Given this list of marker genes Zfyve26, Il16, Alkbh4, Erhrt-ps, Gnai2, Sirt2, Arl3, Mplkip, Mplkipl1, Ankrd45, Ptch1, Cep44, Hnrnpu, Mical1, Ctnnd1, Pkn2, Flcn, Rnf8, Ttc23l, Jtb, Tbck, Wiz, Eml4, Foxl2, Klhl9, Arf6, Ralb, Plk1, Celf2, Tacc1, Arl8b, Defa24, Cenpf, Defa2, Klhdc8b, Pkn1, Mbd5, Cit, Apc2, Cdk1, Rab11fip3, Defa25, Spart, Septin7, Defa5, Poldip2, Ect2, Usp8, Exoc2, Mark4, Agbl5, Dctn3, Abraxas2, Vps4b, Spast, Exoc3, Nek2, Cenpc1, Ptpn13, Chmp4b, Rhoa, Keap1, Rala, Stk17b, Spag5, Ttc28, Dnm2, Erh, Ccdc66, Crmp1, Pkp4 (plakophilin 4), Cdc42, Birc6, Katnbl1, Stx2, Defa3, Pdcd6ip, Defa37, Katnb1, Shcbp1, Anxa11, Rcc2, Vps4a, Rdx, Lzts2, Defa41, Septin12, Gdi1, Rack1, Urb2, Mak, Chmp5, Prc1, Cenpe, Lats1, Sccpdh, Chmp1a, Rap2a, Chmp6, Defa28, Dapk3, Chmp3, Chmp2a, Gnl3, Psrc1, Tex14, C9orf72, Cep126, Entr1, Ddx11, Exoc5, Chmp2b, Arl8a, Txndc9, Rab11fip4, Pitpnm1, Zfyve19, Ssh1, Bcl3, Clic4, Chmp7, Agap2, Uvrag, Gnai1, Kif23, Usp3, Nat10, Slc2a1, Gem, Defa17, Ttll12, Cyld, Ankrd54 (ankyrin repeat domain 54), Mical3, Incenp, Ctdp1, Anxa2, Aurkc, Rad21, Kif14, Defa26, Cdca8, Septin6, Pdxp, Kif20a, Vamp8, Defa40, Nup62, Triobp, Defa27, Map10, Sh3glb1, Fam50b, Mitd1, Firrm, Exoc6, Hepacam2, Exoc7, Defa30, Ran, Kif20b, Atxn10, Pin1, Mtcl1, Defa34, Iqgap1, Arhgap33os (Rho GTPase activating protein 33, opposite strand), Ccdc69, Aspm, Septin1, Tsg101, Gnai3 (NCBI Gene Id 99910), Pik3c3 (phosphatidylinositol 3-kinase catalytic subunit type 3), Chmp1b, Cpeb3, Rab8a, Zfp330, Defa31, Trappc14 (trafficking protein particle complex 14), Rasgef1b, Cntrl, Safb, Kif4, Lyrm1, Mapre3, Capg, Mtcl2, Msra, Cep55, AY761185, Racgap1, Kif13a, Defa36, Septin2, Anln, Ppp1cc (protein phosphatase 1 catalytic subunit gamma), Cenpv, Chmp4c, Chmp1b2, Kif3b, Svil, Birc5, Defa35, Map7d2, Usp50, Katna1, Nexmif, Ccdc124, Aurkb, Hsp90b1 (heat shock protein 90, beta (Grp94), member 1), Vps37b, Nudc, Arl2bp, Eml3, Ssna1, Myh10, Or2a7, Ypel5, Defa23, Exoc4, Pik3cb, Hspa5, BC004004, Exoc1, Ist1, Luzp1, Dtnbp1, here is a description of the gene set: studied in species Mus musculus Mouse Gene Set: GOCC_MIDBODY A thin cytoplasmic bridge formed between daughter cells at the end of cytokinesis. The midbody forms where the contractile ring constricts, and may persist for some time before finally breaking to complete cytokinesis.